The following is a description of a gene set: Transient ischemic attack Human Gene Set: HP_TRANSIENT_ISCHEMIC_ATTACK species: Homo sapiens, and this is the list of marker genes: TP53, MLX, MYBPC3, THSD4, SMARCAL1, MPL, ELN, GDF2, THSD1, FBN1, ACVRL1, TGFB3, TGFBR2, SMAD4, TLL1, HTRA1, LOX, MYH6, LMNA, SH2B3, SMAD3, FOXE3, GATA4, TGFBR1, HEY2, ACTG1 (NCBI Gene Id 71), NOTCH3, IL12B, ADA2, ANO1, TBX20, ANGPTL6, CALR, JAK2, COL3A1, ACTC1, CITED2, ACTA2, RNF213, GATA6, PRKG1, ABCC6, ENG, KRAS, NKX2-5, MYH11, ACTB, TGFBR3 (NCBI Gene Id 7049), SON, MFAP5, ENPP1, MYLK, THPO, ADAMTS13, HLA-B, TGFB2, SMAD2 (SMAD family member 2), GLA, ZMPSTE24, TET2, MAT2A